The following is a description of a gene set: Human Gene Set: GSE6092_IFNG_VS_IFNG_AND_B_BURGDORFERI_INF_ENDOTHELIAL_CELL_UP species: Homo sapiens Genes up-regulated in endothelial cells: IFNG versus IFNG and B. burgdoferi. Borrelia burgdorferi, the agent of Lyme disease, promotes pro-inflammatory changes in endothelium that lead to the recruitment of leukocytes. The host immune response to infection results in increased levels of IFN-gamma in the serum and lesions of Lyme disease patients that correlate with greater severity of disease. Therefore, the effect of IFN-gamma on the gene expression profile of primary human endothelial cells exposed to B. burgdorferi was determined. B. burgdorferi and IFN-gamma synergistically augmented the expression of genes, seven of which encode chemokines. Six of these (CCL7, CCL8, CX3CL1, CXCL9, CXCL10, and CXCL11) attract T lymphocytes, and one (CXCL2) is specific for neutrophils. Synergistic production of the attractants for T cells was confirmed at the protein level. IL-1beta, TNF-alpha, and LPS also cooperated with IFN-gamma to induce synergistic production of CXCL10 by endothelium, indicating that IFN-gamma potentiates inflammation in concert with a variety of mediators. An in vitro model of the blood vessel wall revealed that an increased number of human T lymphocytes traversed endothelium exposed to B. burgdorferi and IFN-gamma, as compared to unstimulated endothelial monolayers. In contrast, addition of IFN-gamma diminished the migration of neutrophils across B. burgdorferi-activated endothelium. IFN-gamma thus alters gene expression by endothelium exposed to B. burgdorferi in a manner that promotes recruitment of T cells and suppresses that of neutrophils. This modulation may facilitate the development of chronic inflammatory lesions in Lyme disease. from publication Dame TM, Orenzoff BL, Palmer LE, Furie MB (PMID 17202382), and this is the list of marker genes: ZC4H2, PLXNB2, MBLAC2, SNX29, LRATD2, XPR1, S1PR1, TPCN2, TSC22D3, LTA4H, SORD, WDR45, NAGLU, TBXAS1, FBXO21, SLC66A2, LFNG, ACOT2, STX3, MAN1C1, SLC16A6, KIF13B, SOCS6, IL7R, FRY, APPL2, CBR3, TMC6, TTYH2, SPICE1 (NCBI Gene Id 152185), PPARD, PRKACB (NCBI Gene Id 5567), MPEG1, PLEKHM1, NME3, MCOLN1, ENGASE, CAPRIN2, STAMBPL1, ADI1, LIMK2 (LIM domain kinase 2), CNR2, SNX30, RAD51D, CSRNP2, FAM234A, RGS2, SGPP1, CASTOR2, MCM7, DUSP22, CD81, SESN1, GOT2, HIP1, LPAR5 (NCBI Gene Id 57121), MMP19, PLEKHG3, SKI, ACSS1, AAAS, MIB2, MOCOS, NR2C2, PTPN22, TNRC6B, KIF21B, ATOSA, CTDSP2 (NCBI Gene Id 51589), HIPK1, SMPD2, EIF4B, PLEKHO1, RAB3IL1, SLC27A1, PNPO, KHK, MAP3K1, ADAM22 (NCBI Gene Id 53616), MSRB1, ADAM8, XXYLT1, SLC45A4, GTF2I, MOSPD1, ALOX5AP, GLUL, VGLL4, LPXN, IRAG2, HS2ST1 (heparan sulfate 2-O-sulfotransferase 1), MFSD11, TLR4, GYG1, EZH1, GNA12 (G protein subunit alpha 12), CERK, CD300C, SEC22C, TNFAIP8L2, SNX8 (sorting nexin 8), FBLIM1, PLEKHM2, KCNJ10, IL6ST (interleukin 6 cytokine family signal transducer), DUSP7, CYB5R1, LBH, CUX1 (cut like homeobox 1), PHKA2, FHIP1B, PGAP6, MBP, PINK1, KDM7A (NCBI Gene Id 80853), SNX33, EIF4G3, PCMTD1, ZFP36L2, CCPG1, PAQR7 (progestin and adipoQ receptor family member 7), PIP4K2A, MAVS, GPRC5C, FLI1, TPRA1, TSPAN4, RHOJ, ATP6V0A1, ABL1, BIN1, TIAM1, SNX24, MCCC2, FRAT1, ALDH9A1, NQO2, ARL11, EXOC6, PXMP4, TPCN1, KANK2, DUSP3 (dual specificity phosphatase 3), FAM3C, NCOA3, IFT74, ZFYVE26, PTGS1, BBS9, PLAG1, POLG2, CD84, FMNL1, CELF2, RGS10, CD180, CD200R1, IRF8, PDXK, WWP1, BTBD2, PLOD1, SYNGR1, TEC, HP1BP3, GSN, PER3, ATP13A2, PCYOX1, BHLHE41, STRBP, ZDHHC14, ADAMTS10, FNIP2, ANGPTL4, TTLL5, NEK6, RAB3A, TMEM65, ITGA6